The following is a description of a gene set: Human Gene Set: GOBP_VOLUNTARY_SKELETAL_MUSCLE_CONTRACTION A process in which force is generated within voluntary skeletal muscle tissue, resulting in a change in muscle geometry. Force generation involves a chemo-mechanical energy conversion step that is carried out by the actin/myosin complex activity, which generates force through ATP hydrolysis. In the voluntary skeletal muscle, the muscle contraction takes advantage of an ordered sarcomeric structure and it is under voluntary control. Voluntary skeletal muscle is skeletal muscle that is under conscious control. species: Homo sapiens, and this is the list of marker genes: ATP2A1, TNNT1, SYNM, STRIT1, ACTN3, MYH7